Given this list of marker genes SIRT7, WDR75, UBTF, DEK (NCBI Gene Id 7913), MYO1C, NOL11, CARM1, BNC1, WDR43 (NCBI Gene Id 23160), DHX33, SMARCA5, SF3B1, LYAR, RASL11A, EIF2AK3, NCL, PIH1D1, BAZ1B, UTP15, DDX21, ATF4, MYBBP1A, UBTFL1, SMARCB1, MTOR, SMARCA4 (NCBI Gene Id 6597), PHF8, MARS1, PWP1, ERCC6, IPPK, DDX11, ERBB2, ACTR6, UBTFL6, HEATR1, here is a description of the gene set: Human Gene Set: GOBP_POSITIVE_REGULATION_OF_TRANSCRIPTION_BY_RNA_POLYMERASE_I Any process that activates or increases the frequency, rate or extent of transcription mediated by RNA polymerase I. species: Homo sapiens